The following is a description of a gene set: Anomaly of the visual evoked potentials elicited by a flash stimulus, generally a flash of light subtending an angle of at least 20 degrees of the visual field and presented in a dimly lit room. Abnormal flash visual evoked potentials studied in species Homo sapiens Human Gene Set: HP_ABNORMAL_FLASH_VISUAL_EVOKED_POTENTIALS, and this is the list of marker genes: ATXN1, POMGNT1, ITPR1, GALC, SCAPER